The following is a description of a gene set: The process in which a relatively unspecialized cell acquires specialized features of a columnar/cuboidal epithelial cell of the intestine. Human Gene Set: GOBP_INTESTINAL_EPITHELIAL_CELL_DIFFERENTIATION studied in species Homo sapiens, and this is the list of marker genes: PTK6, CBFA2T2, PRDM1, C1GALT1, GATA4, NPY, MIR29B1, HOXA5, SOX9, TLR9, TIGAR, IL6ST, GATA5, SPDEF, YAP1, SAV1, GATA6, TMIGD1 (NCBI Gene Id 388364), KLF5, NKX3-2, FZD5, SRC (SRC proto-oncogene, non-receptor tyrosine kinase), YIPF6, HIF1A, PYY, CDX2